Given this list of marker genes Tsc22d1, Per2, Actb, Spin1, Hap1, Trhr, Tef, Dynlt1c, Dkk3, Wdr6, Grb2, Iqgap2, Cpne6, Kcna4, Hes5, Pnck, Nnat, Amy1, Rbck1, Zbtb20, Aqr, Aass, Pdrg1, Ptch1, Pdxk, Prkch, Pou3f4, Sox11, Ets2, Cadm1, Penk, H2-T24, Txnrd1, Pdyn (NCBI Gene Id 18610), Pkp2, Ccdc88a, Foxp1, Man1a, C4b, Gemin5, Ldb2, Doc2b, Pla2g12a, Dhcr7, Ago2, Adissp, Pbx3, Col6a1, Atp11a, Arglu1, Arf3, Skp1, Cry1, Epb41, Plagl1, Six3, Ptprm, here is a description of the gene set: studied in species Mus musculus DeltaFosB (a truncated form of FosB) and CREB (cAMP response element binding protein) are transcription factors induced in the brain's reward pathways after chronic exposure to drugs of abuse. However, their mechanisms of action and the genes they regulate remain unclear. Using microarray analysis in the nucleus accumbens of inducible transgenic mice, we found that CREB and a dominant-negative CREB have opposite effects on gene expression, as do prolonged expression of DeltaFosB and the activator protein-1 (AP-1) antagonist DeltacJun. However, unlike CREB, short-term and prolonged DeltaFosB induction had opposing effects on gene expression. Gene expression induced by short-term DeltaFosB and by CREB was strikingly similar, and both reduced the rewarding effects of cocaine, whereas prolonged DeltaFosB expression increased drug reward. Gene expression after a short cocaine treatment was more dependent on CREB, whereas gene expression after a longer cocaine treatment became increasingly DeltaFosB dependent. These findings help define the molecular functions of CREB and DeltaFosB and identify clusters of genes that contribute to cocaine addiction. Genes down-regulated in the nucleus accumbens (a major reward center in the brain) 8 weeks after induction of CREB1 expression in a transgenic Tet-Off system. Mouse Gene Set: MCCLUNG_CREB1_TARGETS_DN from publication McClung CA, Nestler EJ (PMID 14566342)